Given this list of marker genes Rpe65, Stra6, Dhrs9, Ttr, Lrat, Rlbp1, Rbp3, Abca4, Rdh1, Sdr9c7, Rbp4, Rbp1, Myo7a (myosin VIIA), Rdh12, Cyp4v3, Rdh10, Rho, Rdh11, Hsd17b6, Rdh5, here is a description of the gene set: The canonical retinoid cycle in rods (twilight vision) species: Mus musculus Mouse Gene Set: REACTOME_THE_CANONICAL_RETINOID_CYCLE_IN_RODS_TWILIGHT_VISION